The following is a description of a gene set: Mouse Gene Set: WP_MECHANISMS_ASSOCIATED_WITH_PLURIPOTENCY species: Mus musculus Mechanisms associated with pluripotency, and this is the list of marker genes: Kdm1a (NCBI Gene Id 99982), Satb1, Relb (NCBI Gene Id 19698), Gab1, Yy1, Pin1, Kdm6a, Tfe3, Ezh1, Rybp (NCBI Gene Id 73651), Rel, Hdac4, Esrrb, Atrx, Cad, Fos, Gatad2a, Shh, Sp3, Jarid2, Notch1, Prkcg, Uhrf1, Sf1, Smad7, Rbpj, Tle2, Tfap2c, Bmp4, Rbbp7, Rock2, Kat5, Npr1, Nfkb1, P4ha1, Ipo9, Dffa, Ppp2r1a, Sgk1, Niban1, Suz12, Casp3, Rbl2, Utf1, Tgfb1, Nme2, Gadd45gip1, Pml, Kpnb1, Cd44, Ehmt1, Skic8, Acvr1b (activin A receptor, type 1B), Terf2, Tcl1, Smarca5, Thap11, Trim24, Zfp219, Hras, Zic3, T, Smarca2, Apc, Trim28, Brca1, Ewsr1, Smarcc1, H3f3a, Gbx2, Ep300, Ercc5, Tfap2a, Eed, Inhbb, Tle4, Rybp-ps, Tbx3, Kdm3a, Il6st, Rnf2 (ring finger protein 2), Smad2, Nodal, Mapk3, Lif, Cer1, Ptprs, Twist1, Hand2, Tfcp2l1, Sall4, Bmpr2, Kdm5c, Mapk1 (mitogen-activated protein kinase 1), Jade1, Pik3cd, Smarca4, Spp1, Kmt2d, Rock1, Id1, Wwp2, Smurf1, Igfbp3, Etv5, Nr2f1, Ctr9, Nanog, Gsk3b, Mtf2, Smad4 (SMAD family member 4), Mitf, Otx2, Zfp281, Ctbp1, Fbxo15, Smad1, Dnmt3b (DNA methyltransferase 3B), Pim3, Pou2f1, Psen1, Rcn2, Nppb, Tcf7, Nacc1, Zic2, Chd4, Nr2f2, Cabin1, Prkaca, Ssrp1, Fgf4, Nobox, Lef1, Klf5, Smo, Yipf2, Mta2, Xpo4, Gata6, Foxd3, Dgka, Myod1 (myogenic differentiation 1), Leo1, Tfeb, Cdk2ap1, Gatad2b, Phc1, Pbrm1, Xist, Raf1, Ocln, Icam1, Lifr, Rif1 (replication timing regulatory factor 1), Dppa4, Sall1, Dnmt1, Ins1, Ehmt2, Crebbp, Ncoa1, Wnt5a, Sin3a, Hdac2, Ddb1 (damage specific DNA binding protein 1), Zfp42, Nr0b1, Irs1, Mta1, Mef2d, Mef2c, Satb2, Ctnnb1, Gdf9, Trp53 (NCBI Gene Id 22059), Gadd45a, Atf2, Dazl, Eras, Lefty1, Fgf5, Cdc73, Nedd4l, Paf1, Nr2f6, Insr, Wnt3a, Pias2, Cdk2, Tle5, Cers2, Lyar, Creb1, Cubn, Zfp143 (NCBI Gene Id 52416), Smarcad1, Rras, Myc, Sall3, Rela, Dnmt3l, Tpo, Cdh1, Socs2, Dhx9, Mbd3, Acvr1, Kpna2, Usp7, Perp, Ipo7, Dkk1, Ctbp2, Parp1, Smad3, Ogt, Stat3, Sos1, Klf2, Zscan10 (NCBI Gene Id 332221), Pias4, Fzd1, Hck, Plet1, Sumo1, Mycn, Stk40, Nr2c1, Map2k1, Axin1, Zmym2, Bcam, Pten, Mbd2, Grsf1, Zfp57, Tcf7l1, Arid3b, Cdkn1a, Rtn4r, Nkd1, Kdm6b, Zfx, Tet1, Ube2i, Kdm4c, Nr5a2, Dpysl2, Trim33, Tgfbr1 (NCBI Gene Id 674605), Pim1, Med12, Cdkn2a, Hells, Mdm2, Lrp5, Ep400, Grb2 (NCBI Gene Id 14784), Mybl2, Epop, Dnmt3a, Rest, Jak1, Elp4, Hira, Ncl, Fgfr1, Hnrnpu, Ctcf, Hdac1, Ccnd1, Klf4, Sp1, Dvl1, Sox2, Rbbp4, Ezh2, Rcor2, Tert, Tsix, Mpl, Pou5f1, Akt1, Acvr1c, Mtor, Cdx2, Hif1a, Hcfc1, Ptpn11, Itgb1